Given this list of marker genes Ctnna1, Cyp1b1, Jup, Ctnnb1, Cdh1, Brca1, here is a description of the gene set: Mouse Gene Set: GOBP_RESPONSE_TO_INDOLE_3_METHANOL species: Mus musculus Any process that results in a change in state or activity of a cell or an organism (in terms of movement, secretion, enzyme production, gene expression, etc.) as a result of an indole-3-methanol stimulus.